Given this list of marker genes PADI6, TLE6, KHDC3L, NLRP5, OOEP, here is a description of the gene set: species: Homo sapiens The action of a molecule that contributes to the structural integrity of cytoplasmic lattice of the the mammalian ooplasm. Human Gene Set: GOMF_STRUCTURAL_CONSTITUENT_OF_CYTOPLASMIC_LATTICE